Given this list of marker genes Napepld, Nmu, Cck, Npsr1, Lepr, Fto, Ttc21b, here is a description of the gene set: studied in species Mus musculus Mouse Gene Set: GOBP_NEGATIVE_REGULATION_OF_EATING_BEHAVIOR Any process that stops, prevents or reduces the frequency, rate or extent of eating behavior.